The following is a description of a gene set: Human Gene Set: GOBP_PROTEIN_DEPOLYMERIZATION The process in which protein polymers, compounds composed of a large number of component monomers, are broken down. Depolymerization occurs by the successive removal of monomers from an existing poly- or oligomeric protein. species: Homo sapiens, and this is the list of marker genes: KATNB1, MICAL3, LMOD1, KIF2C, APC, CFL2, WASHC2C, KIF18B (kinesin family member 18B), STMN4, VPS4B, NCKAP5, SCIN, TRIOBP, SLN, SEMA5A, SPTA1, ADD3, SPECC1L, ARHGEF2, FGF13, AVIL, BMERB1, AURKB, CLASP2, APC2, DIAPH3, SPTBN4, CKAP5, ADD2, EPS8, TMOD3, CAPZA2, ASB2, CLTC, GSN, ATXN7, CAMSAP2, VIL1, CAPZB, CAPZA3, SYNJ1, SVIL, GAK, SPEF1, WDR1, LMOD2, TPX2, PDXP, MICAL2, MAP1B, CARMIL1, KIF14, KIF2A, PPP1R9B, ACTN2, TAOK1, KIF19, CIB1, KIF24, MID1, KIF18A, DMTN, PLEKHH2, GAS2L1, HDAC6, CAPG (NCBI Gene Id 822), MID1IP1, CKAP2, ADD1, MICAL1, TRIM54, FLII, PLEK, RDX, SPTBN2, TMOD1, SPAST (NCBI Gene Id 6683), CARMIL2, DNAJC6, PIK3CA, SH3BP1, MAP1A, TWF2, TTBK2, KIF21A, NES, STMN2, SPTBN1, HDGFL3, KIF2B, CRACD, VILL, LIMA1, SWAP70, TMOD2 (tropomodulin 2), F2RL1, CLASP1, MAP1S, WDR47 (NCBI Gene Id 22911), CAPZA1, TWF1, VPS4A, TRPV4, NAV3, CFL1, BBOF1, TMOD4, MTPN, STMN3, HSPA8, SPTBN5, ASPH, LMOD3, CCDC88C, NCKAP5L, CCSAP, STMN1, MAP6D1, SPTAN1, SPTB, DSTN (NCBI Gene Id 11034), GAS2L2